Given this list of marker genes SRSF1, U2AF1, SRSF10, SRSF12, RBM39 (RNA binding motif protein 39), LUC7L, here is a description of the gene set: Binding to an RS domain of a protein; RS domains are usually highly phosphorylated and characterized by the presence of arginine (R)/serine (S) dipeptides. The RS domain promotes protein-protein interactions and directs subcellular localization and, in certain situations, nucleocytoplasmic shuttling of individual SR proteins. They also play a role in splicing. Human Gene Set: GOMF_RS_DOMAIN_BINDING species: Homo sapiens